The following is a description of a gene set: MicroRNA (miRNA) biogenesis Mouse Gene Set: REACTOME_MICRORNA_MIRNA_BIOGENESIS species: Mus musculus, and this is the list of marker genes: Ago4, Ago3, Tarbp2 (TARBP2, RISC loading complex RNA binding subunit), Prkra, Ago1, Ago2